The following is a description of a gene set: species: Mus musculus A complex composed of TATA binding protein (TBP) and TBP associated factors (TAFs); the total mass is typically about 800 kDa. Most of the TAFs are conserved across species. In TATA-containing promoters for RNA polymerase II (Pol II), TFIID is believed to recognize at least two distinct elements, the TATA element and a downstream promoter element. TFIID is also involved in recognition of TATA-less Pol II promoters. Binding of TFIID to DNA is necessary but not sufficient for transcription initiation from most RNA polymerase II promoters. Mouse Gene Set: GOCC_TRANSCRIPTION_FACTOR_TFIID_COMPLEX, and this is the list of marker genes: Taf9b, Taf6, Taf2 (TATA-box binding protein associated factor 2), Taf5 (TATA-box binding protein associated factor 5), Taf7l, Gtf2a2, Tcea1, Taf13, Ercc2, Gtf2h5, Taf3, Gtf2f1, Ercc3, Taf10, Taf4b, Tbp, Gtf2e1, Taf8, Taf1, Taf5l, Taf6l, Taf7, Taf4, Gtf2a1, Gtf2b, Gtf2h3, Gtf2e2, Gtf2h4, Gtf2h2, Taf12, Taf9, Taf11